The following is a description of a gene set: studied in species Mus musculus Mouse Gene Set: GOBP_REGULATION_OF_MICROTUBULE_DEPOLYMERIZATION Any process that modulates the frequency, rate or extent of microtubule depolymerization., and this is the list of marker genes: Gas2l1, Camsap3, Stmn2, Map1a, Apc2, Diaph3, Aurkb, Bmerb1, Cib1, Spast, Map2, Kif21a, Clasp1, Htr1a, Wdr47, Mid1, Mid1ip1, Tpx2, Bbof1 (NCBI Gene Id 72873), Nav3, Taok1, Rp1, Camsap1, Gas2l2, Eml4, Ckap2, Trpv4, Apc, Ccdc88c, Atxn7 (ataxin 7), Fgf13, Map1s, Katnb1, Specc1l, Ttbk2, Map1b, Clasp2, Trim54, Arhgef2, Hdgfl3, Camsap2, Map6d1, Spef1, Hdac6